Given this list of marker genes DLST, MMP2, PPP2CB, TFB2M, FADS1, DCXR, EIF3E, TUBA1B, GLO1, FDPS, CYP11B2, EEF1AKMT1, MRPL42, DESI2, BUB1, NUF2, OSTC, FCER1G, MMACHC, VAMP7, ASNSD1, NIBAN2, AZIN1, SOD2, SERP1 (NCBI Gene Id 27230), MMP7, CDH8, MLEC, PSME3, GUSB, HJURP, RPL19, PVT1, FDFT1, CDC25C, UBE2A, POFUT2, ACSL5, POLRMT, MED21, CSNK2A1, AAAS, MRPL45, ABCA7, UBAP2L, WNT3 (NCBI Gene Id 7473), SERPINB11, NCBP1, BMP1, CYB5A, RALGAPA1, PPP5C (NCBI Gene Id 5536), ELP2, PTPRE, OLFML3, DHFR, EIF1AX (eukaryotic translation initiation factor 1A X-linked), NOL11, COX20, PYGL, SLC30A4, EREG (NCBI Gene Id 2069), PGRMC1, SLC4A7, SEZ6L2, GPD2, EIF2S3, PSMD7, CSDE1, SURF4, FAM43A, CDPF1, MGAT2, SKIC8, TSR1, NARF, BAIAP3, ZNF106, MRPL35, PRADC1, PIKFYVE, DNAJB8, BICD1, SASH1, CLPP, SCAMP1, GALNT6, QSOX1, FAM8A1, CDK2AP2, PPBP (pro-platelet basic protein), RABIF (NCBI Gene Id 5877), PPP3CB, DENND10, CNN1, WDR45B, CDK4, CLK2, EXOSC10, NLGN1, MIGA2, BPNT1, ACACA, ATXN10, ZC3H14 (NCBI Gene Id 79882), FUOM, NF2, CERS2, DUSP26, CTBS, MCUB, TXNDC12, SPN, FAM220A, APEX1, NOP14, ORMDL2, MED22, CFTR, ANAPC16, ERBB4, TPBG, ARFGAP3, AMPD2, RAD9B, PLA2G5, BIRC5, KIF13A, FAR1, TMCO1, NPPC, CDKN2B, PRPS1, ACTN4, SEL1L3, CAV2, IMPDH2, PLPP1, RTL8C, HSPH1, TMEM165, TRIAP1, IGF2BP2, CD2BP2, NUS1, WIPI1, DHCR24, MGA, SLC25A35, AP2A2, CEP290, OPHN1, YAF2, CALN1, DBT, CERS5, NUDCD1, STARD4, NR5A1, UGGT2, COPE, ZNF48, NOP10, KRT17, EIF3L, ATP6V0A1, CENPK, IL36G, WDR26, SIGLEC7, ZNF239, HSPA1L, PANK1, SNRPA, SH3BGRL3, HDAC6, EIF3J, COQ7, TMEM151B, HMGCS1, ACOX1, PRDX3, SLC48A1, TRIM27, RFK, PRMT3, SEPTIN7, RPL12, UBE2G1, VSTM2B, B4GALT7, STMN1, ANGPTL6, NUP93, TEDC1, LCMT1, SLC25A48, TLR1, LRPPRC, GOPC, here is a description of the gene set: Human Gene Set: GSE17721_POLYIC_VS_CPG_16H_BMDC_DN studied in species Homo sapiens from publication Amit I, Garber M, Chevrier N, Leite AP, Donner Y, Eisenhaure T, Guttman M, Grenier JK, Li W, Zuk O, Schubert LA, Birditt B, Shay T, Goren A, Zhang X, Smith Z, Deering R, McDonald RC, Cabili M, Bernstein BE, Rinn JL, Meissner A, Root DE, Hacohen N, Regev A (PMID 19729616) Genes down-regulated in comparison of dendritic cells (DC) stimulated with poly(I:C) (TLR3 agonist) at 16 h versus DC cells stimulated with CpG DNA (TLR9 agonist) at 16 h. mouse primary BMDCs were stimulated with tlr ligands and gene expression changes were profiled on Affymetrix arrays